The following is a description of a gene set: species: Mus musculus Binding to a death domain of a protein. The death domain (DD) is a homotypic protein interaction module composed of a bundle of six alpha-helices. DD bind each other forming oligomers. Some DD-containing proteins are involved in the regulation of apoptosis and inflammation through their activation of caspases and NF-kappaB. Mouse Gene Set: GOMF_DEATH_DOMAIN_BINDING, and this is the list of marker genes: Tradd, Cradd, Ripk1, Irgm1, Irgm2, Mcl1, Dap, Bcl2, Bax, Bcl2l1, Rack1, Igtp